Given this list of marker genes Ppp5c, Fgd4, Mapkap1, C1qtnf9, Rhoa, Mstn, Mir26b, Txk, Spry4, Unc119 (NCBI Gene Id 64820), Vegfb, Uchl1, Drd2, Wdfy2, Dmpk, Ccl19-ps3, Dclk3 (doublecortin-like kinase 3), Ret, Irs2, Ifng, Pak2, Hspa2, Col6a1, Rspo1, Cemip, Prkca, Ppp1r15b, Stat3, Mydgf, Saa3, Ang4, Ggnbp2, Cacul1, Hdac6, Gadd45b, Atxn1, Pax6, Kirrel2, Mark4 (MAP/microtubule affinity regulating kinase 4), Fastk, Large1, Htt, Map4k3, Hmgcr, Lonp1, Dgka, Il11 (interleukin 11), Gck, Rgs2, Ang5, Cntf, Bmp4, Vtn, Tead1, Tenm1, Stap1, Pkn2, Cx3cl1, Ptk6, Adar, Magi3, Mmd, Dgkg, Aurkb, Pik3cg, Ibtk, Arhgef5, Tmem102, Cdc42, Gp6, Vrk1, Clcf1, Plpp3, Ern1, Stat2, Cryaa, Lilra5, Map4k1, Tpd52l1 (tumor protein D52-like 1), Apc, Camk2g, Hdac3, Bmpr2, Hbb-bs, Pdk3, Fiz1, Vangl2, Trpm7, Nlrp12, Cldn19, Lilrb4a, Adra2a, Rock2, Akap5, Slc8a1, Rbks, Dyrk3, Erc1, Ptk2, Eif2ak1, Xbp1, Mif, Inpp5f, Ctdsp1, Mapk15, Tnfrsf4, Cass4, Smad5, Bmp2, Ptprb, Csnk1e, Nras, Zzef1, Eif2ak2, Ccl5, Firrm, Rarres2, Pck1, Eng (endoglin), Akt2, Trpt1, Map3k1, Pih1d1, Mcm7, Plk2, Adipoq, Hoxb3os, Ppm1f, Tada2a, Ctdsp2, Ccnd1, Enpp1, Map3k4, Camk1, Hax1, Ptprh, Bcl2, Itgb2, Mir423, Ttbk2, Socs5, Ccny, Fgf1, Il23a, Oxsr1, Pak1, Nkx3-1, Tcl1, Irak2, Pik3r3, Fgf18, Spdye4a, Ulk4, Stk11, Lck, Dgkq, Prdx3, Wnt9b, Flt3l, Plk1, Etaa1, Ntrk1, Adcyap1, Il12b, Chp1, Cbl, Pkdcc, Ptk7, Gprc5a, Fgf8, Grk1, Camk4, Hunk, Gskip, Reg3b, Iqgap1, Dusp7, Pkn1, Nod2, Map2k4, Nek7, Tyro3, Zc3h12a, Hk1, Errfi1, Inca1, Dlg1, Cad, Crebl2, Tsg101, Stk39, Ptprj (NCBI Gene Id 98976), Ccl3, Epha3, Alk, Ooep, S1pr2 (NCBI Gene Id 68430), Riok2, Coq8a, Atf2, Tab1, Tnf (NCBI Gene Id 21926), Nuak2, Cd80, Pde5a, Aida, Ikbke, Sez6, Rsrc1, Mtor, Spred1, Cenpe, Dstyk, Galk1 (galactokinase 1), Lats2, Mad2l2, Tm9sf5 (NCBI Gene Id 245423), Ocln, Pdgfb, Ddrgk1, Flt1, Nbn, Ttbk1, Mprip, Pxn, Araf, Mir301, Sh2d1b2, Kit, Psen2, Nlk, Itgb3, Ezh2, Gpr39, Pank3 (pantothenate kinase 3), Reln, Aplp2, Pkib, Cdk2ap1, Tek, Cadm4, Pdgfd, Fmr1, Pebp1, Spry2, Cops2, Jak2, Mlxipl, Rgma, Itln1, Tnfsf11, Stk16, Nrg1, Edn1, Ptpn4, Ccnb1, Snx9, Nox4, Spred2, Dusp10, Melk, Cdk12, Pparg, Mlst8, Aif1, Ube2k, Chga, Nf2, Socs4, Ctf1, Prkcb, Prkci, Prkar1a, Ppme1, Pdgfc, Cnot7, Celsr3, Dusp6, Gckr, Akt1s1, Stk38l, Grb10, Cdkl5, Csnk1d (casein kinase 1, delta), Dock7 (NCBI Gene Id 67299), Lepr, Ppp2ca, Myo3a, Prkd2, Fgr, Rb1, Ripk1, Adnp, Bdnf, Ntrk3, Cldn3, Rit2, Mknk1, Fbln1, Fbxo7, Nup62, Eif4g1, Yes1, Trim27 (NCBI Gene Id 19720), Flot1, Cdkn1a, Rps23rg1, Ddr2, Mapk9, Prkg1, Dynapl1, Dab2, Ccl19-ps6, Nuak1, Prom2, Aatk, Tlr8, Jak3, Tspyl2, Bag1, Smad7, Zfp622, Lmo4, Insrr, Ptpn13, Fzd4, Tnfaip3, Tgfb1, Ptgis, Cd300a, Hsf1, Cd74, Efemp1, Trpc6, Qars1, Oprd1, Camk2b, Smyd3, Sirt1, Il13, Mir875, Ifnar1, Ccne1, Cimap3, Uvrag (UV radiation resistance associated gene), Brsk1, Ugt1a1, Tnk1, Tnks1bp1, Zfyve28, Eif2ak3, Dynap, Mir26a-1, Zgpat, Epha4, Rassf2, Tpx2, Htatip2, Irak3, Il34, Mapk8ip3, Abl1, Trib1, Il12rb1, Wnk1, Bdkrb1, Pik3ca, Tssk4, Slc8a2, Stat4, Clk3, Wnk2, Dnajc10, Avp, Prkar1b, Tlk1, Ulk1, Prrt1, Grem1, Zeb2, Fbh1, Bak1, Traf3ip1, Sez6l, Phip, Cdk5rap1 (CDK5 regulatory subunit associated protein 1), Kdm4d, Rapgef2, Prkx, Itgb1bp1 (integrin beta 1 binding protein 1), Gsk3b, Smad9, Myocd, Mrnip, Pla2g6, Uhmk1, Ntrk2, Ptprz1, Cd40, Cox11, Mir409, Kras, Cadm1, Dusp19, Tnk2 (NCBI Gene Id 53909), Hus1, Prkcg, Mst1r, Paqr3, Invs, Fem1a, Adarb1, Mcph1, Pik3c3, Smad2, Ppp1r15a, Rara, Fgfr3, Fas, Ereg, Igf1r, Fzd5, Ddx3x, Stradb, Etnk2, Gdnf, Hspb1 (heat shock protein 1), Neurl1a, Clec7a, Ptges3-ps, Map3k3, Ksr1, Tgfbr2, Als2, Egf, Dgke (NCBI Gene Id 97759), Map2k3, Cep43, Ltk, Prr5l, Stk24, Ccnyl1, Pskh1, Ptpn6, Ndp, Gstp3, Map3k9, Eif2ak4, Chuk, Aurka, Chrna7, Park7, Snhg20, Coro1c, Ppp2r5d, Map3k13, Parp9, Ros1, Rps6ka5, Edn3, Ctsg, Stk10, Ighm (NCBI Gene Id 432703), Macroh2a1, Casp3, C9orf72, Lats1, Tardbp, L1cam, Sgk1, Ropn1, Clk1, Cblc, Akt3, Ccnd2, Ctdspl, Hmgb1, Mark2, Ankrd54, Ptges3, Prkab1 (protein kinase, AMP-activated, beta 1 non-catalytic subunit), Prkch, Pim2, Arhgef2, Rasip1, Tgfa, Ep300 (E1A binding protein p300), Shb, Cntn1, Mapk6, Abi2, Prkra, Erbb2, Ptpra, Vegfc, Pim3, Pip5kl1, Agk, Mapre3, Pid1, Srpk2, Fzd7, Dynll1, St3gal1, Hrg, Ip6k2, Btk, Pdcl3, Creb1, Agrn, Chek2, Brd4, Mapk13, Mob1b, Fn1, Pin1rt1, Mapk8, Prkcq (NCBI Gene Id 99373), Rasa1, Lrp6, Brsk2, Chek1, Cdkn2b, Mark3, Gnptab, Prkcz, Notch2 (notch 2), Zbed3, Lama1, Csnk2a1, Csf1, Plec, Pbk, Chmp6, Trim6, Fzd8, Ang (NCBI Gene Id 11727), Mylk2, Dscam, Dvl1, Limch1, Il31ra, Itk, Ccnt1, Grk2, Runx3, Ttk, Dok7, Hkdc1, Shpk, Pik3r5, Cav2, Tigar, Hipk4, Xylb, Fgfr1, Map3k20, Mapkapk5, Gnptg, Trf, Csnk1a1, Slc11a1, Fshr (NCBI Gene Id 14309), Pard6a, Jtb, Lrp8 (NCBI Gene Id 16975), Hk3, Aurkc, Hes5, Birc5, Myo3b, Synpo2, Vps25, Hk2, Hmga2, Wnt11, Fcsk, 2610042L04Rik, Hpx, Angpt1, Ptpn1, Ralbp1, Smg8, Cripto, Pfkm, Card14 (NCBI Gene Id 170720), Ptpn11, Ppp2r5b, Ppp2r3c, Tgfbr1, Itga5 (integrin alpha 5 (fibronectin receptor alpha)), Fggy, Dvl2, Phlpp1, Htr2a, Csk, Pask, Cck, Itgb2l, Ywhaz, Hbegf, Bax, Ccl19-ps5 (NCBI Gene Id 100039789), Gas6, Ern2, Cib1, Cd3e, Men1, Birc3, Gper1, Psmd10, Traf4, Pecam1, Nppa, Wars1, Srpk3, Ptprc, Hnf4a, Jak1, Iqgap3, Sh3gl2, Plxnb2, Srpk1, Pfkfb1 (NCBI Gene Id 18639), Ceacam1, Ephb1, Dgkd, Prkag1, Fer, Pdgfrb, Mapk1, Nek11, Slc8a3, Rac1, Sash1, Arrb1, Pdgfa, Il7, Nagk, Thpo, Stk31, Pink1, Nf1, Dapk2, Emp2, Smad1, Mas1, Rps3, Nim1k, Ptger3, Cilk1, Hes1, Pard3 (NCBI Gene Id 93742), Lrrk1, Raf1, Erbb4, Aktip, Mink1, Map3k7, Rps6ka1, Nek4, Ccl19, Epo, Vrk2, Cdkn2c, Atg14, Trpc5, Grk5, Glyctk, Rgcc, Cnot9, Chrna3, Csnk2b, Cfl1, Mapk14, Fgf7, Cd6, Pick1, Traf6, Ccl19-ps1, Rad50, Bag4, Aplnr, Kndc1, Haspin, Pdcd10 (NCBI Gene Id 80414), Itpkb, Cdkn2a, Dapk3, Dgki, Cxcr4 (C-X-C motif chemokine receptor 4), Nek10, Klhl31, Cactin, Obscn, Tnik (TRAF2 and NCK interacting kinase), Stk4, Smo, Midn, Acvr2a, Glmn, Wee1 (NCBI Gene Id 22390), Nek2, Kat2b, Spry1, Hipk3, Txn1, Camk2a, Ptpn22, Igfbp3, Ppm1e, Itpripl1, Il4, Smtnl1, Ang2, Flt3, Ctnnd1, Cdk9, Bcl10, Clk2, Ephb3, Clspn, Lrrn3, Morc3, Faxdc2, Mylk3, Ogt, Ajuba, Nck1, Khk, Ephb4, Myadm (NCBI Gene Id 50918), Khdc3, Il15, Crkl, Tab2, Sik3, Mapk8ip1, Ldb2, Prkn, Cdk5, Csf3, Odam, Cspg4, Dclk2, Ttc36, Abi3, Camkk2 (calcium/calmodulin-dependent protein kinase kinase 2, beta), Taf7, Fam20c, Stk33, Stat5a (NCBI Gene Id 20850), Mre11a, Ddr1, Mknk2, Eif2a, Ropn1l, Fndc1, Cdk1 (NCBI Gene Id 12534), Il6, Tssk6, Rictor, Rock1, Syk, Acvr1b, Taok3, Adra2c, Pde4d, Pfkfb4, Xrcc6, Cdc42bpa, Kdr, Igtp, Fech, Nsd1, Dguok, Ehd4, Ncl, Adcy8, Smg1, Cav1, Il5, Ifnz, Dnajc3, Dyrk2, Tlr9, Slk, Tnfsf18, Jun, Ppargc1a, Ankle2, Adrb2 (adrenergic receptor, beta 2), Tlr3, Fgfr4, Apoe, Il21, Prr5, Il3, Il12rb2, Zap70, Dgkb, Spatc1l, Gnas, Ilf3, Apoa1, Nrbf2 (nuclear receptor binding factor 2), Strada, Ptger4, Rap2a, Stil, Ccdc88a, Tcim, Epm2a, Ar, Heg1, Rps6kb1, Fgf4, Nherf1, Rgs14, Camp, Usp25, Atp13a2, Tssk1, Adra2b, Gbp4, Rgn, C3, Tnfrsf18 (tumor necrosis factor receptor superfamily, member 18), Mapkapk2, Prlr, Map2k6, Dbndd2, Prkag2, Pikfyve, Gstp-ps, Cdk2ap1rt, Nckap1l, Fnip1, Ltf, Cln3, Tlk2, Tnfrsf1a, Plaur, Maml1, Ccr7, Irf1, Wnk3, Dvl3, Zfp592, Sphk1, Dnaja3, Fcer1a, Nptn, Rtraf, Dtnbp1, Prnp, Wdr59, Psrc1, Dgkz, Tlr1, Mob2, Ulk2, Hnrnpu, F2, Rps6ka4, Irgm2, Gadd45g, Ccnd3, Il6ra, Thy1, Klhl3, Suz12, Terf2ip, Epsti1, Tollip, Sema7a, Ephb2, Acvr1, Snca, Cnksr3, Cdkn1c, Socs1, Mt3, Egfr, Plk4, Kcnq3, Tbk1, Ldb1, Arl2bp, Ccn1, Tnks, Sema4d, Cdc42bpb, Adcy10, Mst1, Dgkh, Ptpro, Eif4g3, Hyal2, Arrb2, Mllt1, Sfn, Xrcc5, Fam3c, Src, Rap2b, Tlr2, Fabp4, Cx3cr1, Bmx, Tsacc, Parp14, Pdcd4, Maged1, Cdc25b, Braf, Cdk6, Anxa2, Ppp4c, Atxn7, Lmtk2, Pomk, Hhex, Arr3, Prkaca, Mapk12, Ikbkb, Fes, Pkia, Hnf1a, Hspa4, Crh, Hcls1, Tgfb2, Pik3r1, Slco3a1, Isl1, Nlrc5, Ang6, Wnt5a, Ripk2, Il24, Map3k11, Nhlrc1, Il22ra2, Fgf10, Wwtr1, Mapt, Socs3, Bst1, Mapkapk3, Hgs, Gfra1, Prox1, Lrrk2, Senp2, Smpd1, Flt4, Crlf1, Epha8, Trib3, Kirrel1, Cd4, Ccn2, Icam1, Dnaja1, Samsn1, Cd24a, Epha7, Hipk1, Mmp9, Atr, Cdk5r2, Vldlr, Hcst, Fzd1, Cdkn2d, Umod, Prkrip1, Cdkn1b, Niban1, Snrk, Trem2, Irgm1, Itga6, Cdon, Dusp3, Ednra, Ppia, Lrp4, Map4k4, Prkacb, Slit2, Fyn, Sfrp1, Tspan9, Chi3l1, Trim65, Il6st, Abl2, Trib2, Lime1, Ppp1r9b, Kcnq2, Nrxn1, Mark1, Pdgfra, Lif, Mcemp1, Bard1, Il22, Tssk5 (testis-specific serine kinase 5), Ilk, Bank1, Slfn1, Ptprt, Drd4, Ccl19-ps4, Efna1, D1Pas1, Sdcbp, Tirap (toll-interleukin 1 receptor (TIR) domain-containing adaptor protein), Prkd1 (NCBI Gene Id 18760), Ubash3b, Hsp90aa1, Epha1, Robo1, Reg1, Ins1, Rps6kb2, Fgf2, Mast2, Sptbn4, Srms, Dmtn, Csf1r, Blm, Tnfrsf14, Trp53rkb, Mavs, Cep85, Dusp1, Lox (NCBI Gene Id 16948), Dab1, Nop53, Cdk2, Inhba, Irs1, Csf2, Hras, Map3k12, Axin1 (NCBI Gene Id 12005), Adm2, Axin2, Map2k2, Map3k6, Wnt3a, Sirt2, Pim1, Vegfa, Csnk2a2, Pibf1, Nnt, Card10, Dapk1, Blvra, Mast1, Ppp3cb, Il2, Eef2k, Bcar3, Gstp2, Bmp7, Grk3, Gba1, Syap1, Prkdc, Il12a, App, Fbxw7, Cdk5rap3, Prkaa2, Tesk1, Clip3, Cd2ap, Rap2c, Musk, Pkd1, Gprc5b, Cdc37, Tkfc, Nolc1, Rb1cc1, Cav3, Ptpn5 (protein tyrosine phosphatase, non-receptor type 5), Nedd9, Ikbip, Clk4, Hdac2, Dhx34, Fnip2, Drd1, Tada3, Efna5, Gjc2, Adam9, Tbx1, Xdh, Dclk1, Akt1, Ptk2b, Rad51, Insm1, Hrc, Sfrp5, Adtrp, Map3k5 (mitogen-activated protein kinase kinase kinase 5), Gstp1, Cartpt (NCBI Gene Id 27220), Hipk2, Npm1, Akap6, Apln, Gata1, Spn, Nprl2, Dab2ip, Sh3bp5, Tom1l1, Gfra2, Rap1a, Inpp5j, Rabgef1, Hgf, Kctd20, Gadd45a, Tsc1 (TSC complex subunit 1), Kif14, Fkbp8, Ucn, Rorc (NCBI Gene Id 19885), Mir1896, Dyrk1b, Mir26a-2, Cops8, Il9, Galk2, Peak1, Ect2, Rapgef3, Stk3, Cdh5, Ednrb, Sox9, Rasgrp1, Adipor2, P2rx7, Rps6ka2, Kitl, Mak, Trim28, Daxx, Smok2b, Adam17, Enpp2, Sesn2, Il9r, Fbn1, Lep, Gne, Tbck, Ripk3, Wnt1, Adam10 (NCBI Gene Id 67314), Met, Gtpbp4, Wee2, Sod1, Mos, Ptpn2, Limk1, Mvp, Wdr24, Ntf3, Thbs4, Mapk10, Nrp1, Tnfrsf11a, Insr, Sik1 (salt inducible kinase 1), Cd44, Nek3, Zfp91, Phactr1, Tsc2, Fgfr2, Slamf8, Limk2, Spink1, Ralb, Osm, Cdk5r1, Agap2, Ncam1, Fgd2, Stk38, Stk25, Taok1, Slc1a1, Spdya (speedy/RINGO cell cycle regulator family, member A), Htr2b, Higd1a, Rptor, Bccip, Aak1, Ip6k3, Tesk2, Cd109, Zfp418, Fam20a (FAM20A, golgi associated secretory pathway pseudokinase), Srcin1, Pten, Hck, Dusp22, Ins2, Ager, Tfap4, Tssk3, Lyn (LYN proto-oncogene, Src family tyrosine kinase), Atm, Traf2, Tssk2, Il18, Rbl2, Trp53rka (transformation related protein 53 regulating kinase A), Limd1, Tfrc, Cdk4, Prkg2, Tlr4, Prkaa1, Impact, Chordc1, Map3k10, Gpd1l, Gpnmb, Prkce, Sez6l2, Stox1, Wnk4, P2ry1, Pfkfb2, Agt, Nek6, Rho (NCBI Gene Id 212541), Lilrb4b, Pycard, Pfn2, Sqstm1, Akap9, Mapk7, Gpr180, Abi1, Ppargc1b, Ercc6, Hexim2, Ndufs4, Rack1, Ulk3, Akap11, Deptor, Top1 (NCBI Gene Id 98994), Rad17, Comt, Rbl1, Gsk3a, Acp4, Eif2s1, Irak1, C1qtnf4, Map2k7, Areg, Mmd2, Dyrk1a, Sik2, Eef1a2, Prkcd, Dkk1, Nek1, Cdk10, Psen1, Bdkrb2, Ifnb1, Tlr6, Srpx2, Spag9, Ppef2, Gnaq, Camk2d, Stk17b, Pik3r6, Map4k2, Cdc42bpg, Peli2, Thbs1, Trim24, Sh2d1b1, Itgb1, Nos1, Gab1, Garem1, Smpd3, Gm36723, Mapk3, Fgf15, Nr2f2, Pkig, Pin1, Angpt4, Tmed2, Inpp5k, Tlr7, Brat1, Il1b, Erp29, Sfrp2, Cab39, Map2k1, Bmp6, Igf1, Stk26, Blk, Ngf, Coq8b, Osbp, here is a description of the gene set: species: Mus musculus The process of introducing a phosphate group into a molecule, usually with the formation of a phosphoric ester, a phosphoric anhydride or a phosphoric amide. Mouse Gene Set: GOBP_PHOSPHORYLATION